The following is a description of a gene set: The process in which the identity of an animal organ is maintained. Identity is considered to be the aggregate of characteristics by which a structure is recognized. species: Homo sapiens Human Gene Set: GOBP_MAINTENANCE_OF_ANIMAL_ORGAN_IDENTITY, and this is the list of marker genes: ADGRV1, NPHP3, USH2A, IQCB1, PKP2